Given this list of marker genes Il2, Stat5a, Ptpn2, Cited1, Flicr, Stat5b, Jak1, Stat3, Il2ra, Il2rb, Il2rg (NCBI Gene Id 16186), Jak3, here is a description of the gene set: Any process that results in a change in state or activity of a cell or an organism (in terms of movement, secretion, enzyme production, gene expression, etc.) as a result of an interleukin-2 stimulus. Mouse Gene Set: GOBP_RESPONSE_TO_INTERLEUKIN_2 studied in species Mus musculus